Given this list of marker genes SDHD, TBCD (tubulin folding cofactor D), PRDM8, REEP1 (NCBI Gene Id 65055), NDUFA8, POLR3K, GABRA3, ALS2, ATP5MK, SARDH (NCBI Gene Id 8017), MFSD2A, COL4A1, LMX1B, LRP4, PSAP, TRAPPC2L, UGP2, LIPT2, GAD1, ATPAF2, AIFM1, NMNAT1, TBK1, TFG, NNT, VCP, GUF1, SLC19A3, AGTPBP1, TNR, TUBB2B, CACNA1S, CRELD1, RNU7-1, PNP, SLC18A2, CHCHD10, TBCE, ATP1A2, SOD1, PLA2G6, NEXMIF, BCAP31, RANBP2, DPYD, ATP6V1A, EIF2S3, PRF1, MRM2, SLC25A10, GJA1, PRPS1, NUP54, NHLRC2, PAFAH1B1, SLC1A2, ESAM, ARX, SOX4, GSS, NUP62, GALC, NFU1, SLC1A3, COA8, NAXE, KCNQ2, PSEN1, SDHA, HINT1, MC2R, TACO1 (translational activator of cytochrome c oxidase I), CACNA1A, STAMBP, KRAS, DOLK, EIF4A2, NAA60, LIPT1, ATP5F1D, FUS, FAR1, APOE, EARS2, STAR, C9orf72, AUH, ARFGEF2, TRAPPC4 (trafficking protein particle complex subunit 4), ABCD1, PNKP, TMEM222, WDR62, FA2H, SDHB, ADAR, ARSA, ATP5F1E, LMNB1, NDUFS3, PDHX, KCNT1, SDHAF1, SLC35A2, SQSTM1, GM2A, POLG, AFF3, FBLN1, RERE, UCHL1, LYRM7, PIGA, PLP1, ALDH18A1, DYM, KCNJ18, ATP5F1A, L2HGDH, LIMS2, KCNJ6, CARS2, STXBP1, EXOSC8, PHACTR1, TARDBP, SMC1A, PRUNE1, MOCS1, MT-ATP8 (mitochondrially encoded ATP synthase membrane subunit 8), BSCL2, MT-ATP6, SNAPC4, ALG3, BUB1B, CA2, PSAT1, HSD17B10, FGFR1, ERLIN2, TXNRD2, AASS, GBE1, NADK2, PPOX, SELENOI, MRAP, ATP1A3, IFIH1, BCAS3, NEK1, TNFRSF11A, AHDC1, here is a description of the gene set: species: Homo sapiens Human Gene Set: HP_TETRAPLEGIA_TETRAPARESIS Loss of strength in all four limbs. Tetraplegia refers to a complete loss of strength, whereas Tetraparesis refers to an incomplete loss of strength. Tetraplegia/tetraparesis